Given this list of marker genes GET3, PDIA6, PGLS, PEX10, MYDGF (NCBI Gene Id 80302), P4HB (NCBI Gene Id 94756), MLEC, HS3ST3B1, DYNLT1, CRELD1, IAH1, LINC00960, SERINC2, TMCO1, RTRAF, TGFB1I1, ARPC3, LINC01436, TMEM120A, TRIR, COX10, TXNL1, SPCS2, COLGALT1, TMEM134, TRIM47, PMP2, ILVBL, DHCR7, RASD1, MPRIP, TALDO1, DHRS7B, PSMC2, TWF2, TOLLIP, TOM1L2, RRAGA, SCD, URI1, RER1, GTF3C6, MANF (NCBI Gene Id 7873), PKM, EPRS1, ARHGDIA, DUSP14, MESD, C11orf24, RFXANK, TRPV4, TRAPPC3, DYNLRB1, BCAS2, TMEM14C, ALKBH5, VIM, YJU2B, SERPINB5, VMP1, VWA1, SIL1, UBE2J1, ARL6IP5, CHID1, FABP5, C19orf53, P3H3, PSMB2, TRAF4, APMAP, ANGPTL2, CD151, B3GAT3 (NCBI Gene Id 26229), UBE2E3, SDF4, ITIH6, ID2, DDX21, TSPAN4, CLIC3, KRBOX1, SPNS1, SAR1A, ALDH3A2, CSRP1, S100P, TP53I13, TMX1, TRPV2, SOX9, PAPOLA, PHLDA2, GLT8D1 (NCBI Gene Id 91870), GORASP2, CNN3, PIM1, DNASE2 (NCBI Gene Id 1777), HDDC2, DPY30 (NCBI Gene Id 84661), HAPLN1 (NCBI Gene Id 1404), AGA (aspartylglucosaminidase), TMEM11, GDI2, REEP3, CTSA, PTS, PPIL1, BTG3, UBA2, GMDS, CYP1B1, BEX5, PPIB, SLC35B1, UBE2N, TMEM219, CCN6, ELOVL1, ZNF22, GINM1, FADS2, PDIA4, PRKCSH, POMC, RAI1, RPL5, CDKN1C, PEPD, TPBG, ATP5PO, UNC93B1, CD99, PIGP, PYCR1, YIPF2, NCOR1, MAGEH1, TMED10, PRDX2, POP4, USP22, SEL1L, SCO1, PXMP2, ATP6V0B, HEXA, SCUBE3, TMEM101, RPL6, STX8, FRMD6, MRPL37, C6orf89, CISD2, USE1, MAGOH, PDCD5, PSMC1, DNAJB2, SCARB1, PSMD13 (proteasome 26S subunit, non-ATPase 13), CMPK1, ITGB1BP1, FABP3, ATP5MC1 (NCBI Gene Id 516), PTRHD1, NEU1 (neuraminidase 1), PPP1R16A, TMEM98, WDR83OS, SURF4, TVP23B, PYGL, TMEM50B, SPON2, SPINT1, MMP1, NID2, TMEM43, PRPSAP2, DRG2, RBM11, PDLIM5, EMC3, RSU1, TMED1, LAMTOR1, PIGK, SRPRA, P3H1, FAM234A, PEMT, RCN1, MFAP2, RUNX3, CHST3, ULBP2, ERG28, LRPAP1, MMP23B, VKORC1, TUSC3, ATP6AP2, HOXB2, UQCRFS1, NDUFA12, SDF2, ERP44, SEC13, TMEM220, SLC13A5, COPS3, EXT2, TTC3, FLCN, TUBB2A, ARPP19, ATP5PB, FKBP11, VDAC2, LGALS3 (NCBI Gene Id 81625), C19orf12, CHST12, A2M, CBR1, MAN1B1, EIF3M, GPX7, STX10, FABP4, TTC19, FKBP10, TUBB2B, TMEM42, CSPG4, ARMC10, FERMT2, RAET1L, ATPAF2, PHLDA1, LMCD1, TMEM179B, FLII, KCTD5, HSPB1, HNRNPC, MTCH1, RPS3A, OSTC, TMED2, ISG20, HYAL2, ZNF385B, GNG5, OCIAD1, AGPAT2, IFNGR1, CYB5R1, PMP22, RCN2, GIPC1, NUDT14, SSR4, EXTL1, C16orf89, MAPK1IP1L, DNAJB11, FKBP3, MCFD2, GNPNAT1, MED19, SCARB2, LSM2, YIPF4, ITM2A, YIF1A (NCBI Gene Id 10897), PRCP, DLX4, CCS, RNH1, STX5, MATN1, ARSI, CH25H, TENT5A, GLB1, SRI, ZSWIM7, ZFYVE21, RPL15, ZNRD2, RPN2, CTH, SRM, PLEKHF1, ATRAID, CRTAP, MCUR1, AGTRAP, CRELD2, RAB32, PLPP5, AZI2, SCPEP1, YIPF3, HNRNPH3, CNIH1, TUFM, SOD1, LOXL2, P3H4, PSMA4, SSR1, MDH2 (NCBI Gene Id 4191), OGFOD3, FNDC3B, IMPDH2, SGCE, SHISA5, PSMC6, TCP1, TMEM9, PYGB, GID4, ADAMTS1 (NCBI Gene Id 9510), ATP1B3, ARC, ERLEC1, SLC52A2, KRT10, B9D1, WNT11, BCAP31, USP16, SLC39A7, HAPLN3, HTATIP2, PPT1, PIGL, HSPB8, DNAJC4, B4GALT7, SMPD1, MYC, NMT2 (N-myristoyltransferase 2), LRRC59, CDKN2A, TMED3, IL17B, SELENOF, RHOD, PPA1, LY6K, NDUFB7, BZW2, SERPINH1 (NCBI Gene Id 89588), MMP7, CZIB, RPS4Y1, FKBP1A, TNFRSF11B, MATN4, PRDX4 (peroxiredoxin 4), DDOST, HCFC1R1, FN1, NOP10, RPS29, FARSA, CD63, HM13, IFNAR1, RPL18A, SLC39A13, ELAC2 (elaC ribonuclease Z 2), ATP6AP1, GALE, KLHDC2, SREBF1, SNAP29, TMEM123, GPC1, ACTA2, CALR, VASN, SMIM5, SEMA3B, MAP3K13, POLR2G, CPNE1, PIGS, CA2, MICA, TECR, NANS, PLCD1, ERGIC3, LMAN1, HSD17B12, COL11A1, PCOLCE2, FADS1, LINC00511, SLC35B2, DNM3OS, PCMT1, TFPI2, GPRC5C, CDC37, PSMA5, LRRC75A, BABAM1, PPP1R14C, WIPI1, COA8, LEF1, PIGT, SWI5, ATP2B1, PPIC, C1orf122, ANXA2, ERP29, here is a description of the gene set: studied in species Homo sapiens Human Gene Set: SU_HO_CONV_CENT_CHONDROSARCOMA_C3_CHONDROBLASTIC_OSTEOSARCOMA from publication Su Z, Ho JWK, Yau RCH, Lam YL, Shek TWH, Yeung MCF, Chen H, Oreffo ROC, Cheah KSE, Cheung KSC (PMID 38267611) A unique cluster within chondroblastic osteosarcoma samples, expressing genes associated with hypertrophic chondrocyte differentiation, including COL10, SOX9, and LOXL2. This particular cluster is separate from the neoplastic chondrocyte clusters typically associated with CCCS. The transformation of benign lesions to malignant tumours is a crucial aspect of understanding chondrosarcomas, which are malignant cartilage tumours that could develop from benign chondroid lesions. However, the process of malignant transformation for chondroid lesions remains poorly understood, and no reliable markers are available to aid clinical decision-making. To address this issue, we conducted a study analysing 11 primary cartilage tumours and controls using single-cell RNA sequencing. By creating a single-cell atlas, we were able to identify the role of endoplasmic reticulum (ER) stress in the malignant transformation of conventional central chondrosarcomas (CCCS). Our research revealed that lower levels of ER stress promote chondrosarcoma growth in a patient-derived xenograft mouse model, while intensive ER stress reduces primary chondrosarcoma cell viability. Furthermore, we discovered that the NF-?B pathway alleviates ER stress-induced apoptosis during chondrosarcoma progression. Our single-cell signatures and large public data support the use of key ER stress regulators, such as DNA Damage Inducible Transcript 3 (DDIT3; also known as CHOP), as malignant markers for overall patient survival. Ultimately, our study highlights the significant role that ER stress plays in the malignant transformation of cartilaginous tumours and provides a valuable resource for future diagnostic markers and therapeutic strategies.